Given this list of marker genes Gucy1a1, Ins1, Rln1, Vegfa (NCBI Gene Id 22339), Kdr, Pde2a, Gucy1a2, Spink1, Thbs1, Ins2, Cbs, Pde5a, here is a description of the gene set: Any process that modulates the rate, frequency or extent of nitric oxide mediated signal transduction. Nitric oxide mediated signal transduction is The series of molecular signals mediated by the detection of nitric oxide (NO). species: Mus musculus Mouse Gene Set: GOBP_REGULATION_OF_NITRIC_OXIDE_MEDIATED_SIGNAL_TRANSDUCTION